Given this list of marker genes KCNH2, ATP2A1, CAMK2D, JUP, CACNA1G, MYBPC3, GJC1, DLG1, KCNE3, TNNI3, RANGRF, NUP155, SCN8A, PLN, RYR2, ATP1A1, TCAP, MYH8, CACNA1C, ADCY10, NOS1, MYL11 (myosin light chain 11), KCNE4, ACTC1, MIR328, TNNC1, SCN11A, TNNT2, PDE4D, ABCC9, LIMCH1, TTN, GPD1L, SCN2A, MIR133A1, CAV1, KCNN2, MIR1-1, KCNA5, TRPM4, BIN1, RNF207, CASQ2, SCN3B, NEDD4L, EMP2, SUMO1, SLC9A1, KCNE5, GATA4, FLNA, FGF12, QKI, PIK3CA, C10orf71, KCNJ8, SCN1B, FGF13, GJA5, ANK2, STC1, MYH6, LUZP1, MYH3, MYL6B, GJA1, SNTA1, KCNE2, KCNJ5, ROCK1, MYLK2, KCNJ3, EPB41L5, FRMD6, ADORA1, PARVA, MYL6, SGCD, PDE4B, CACNB2, AKAP9, DSP, DSC2, NOS1AP, KCNJ2, MYH2, MIR448, VIL1, SCN7A, SCN4B, MYL1, TPM1, MYH7, CTNNA3, SHTN1 (NCBI Gene Id 57698), SCN1A, SCN2B, PKP2, CAV3, SCN5A, ZEB2, PDPN, HCN4, CACNA1D, KCND3, MYH4, KCNQ1, ATP1A2, KCNE1, ATP2A2, MYH7B, DSG2 (NCBI Gene Id 1829), CACNA2D1 (NCBI Gene Id 781), ACTA2, CCDC88C, GSN, SCN4A (NCBI Gene Id 6329), SCN3A, SCN9A, STRIT1, EPDR1, SRI, SCN10A, here is a description of the gene set: The actin filament-based process in which cytoplasmic actin filaments slide past one another resulting in contraction of all or part of the cell body. species: Homo sapiens Human Gene Set: GOBP_ACTIN_MEDIATED_CELL_CONTRACTION